Given this list of marker genes OPN3 (opsin 3), VPS45, SIRPB1, ZNF737 (NCBI Gene Id 7655), MYEF2 (myelin expression factor 2), CLDN20, ACIN1, KCNC3, SYNM, NAP1L1, PPCDC, RUFY2, EFNA5, ZNF253, TEK, CREBL2, RIBC1, ULBP1, ZNF680, ZNF732, PISD, GTPBP2, SHISA9, ZNF493, ZNF208, ZNF138, HACD3, MBD6, CAPS2, SDK1, ATP23, ELMOD2, PGM2L1, SMU1, KIF16B, ZNF99, ZNF257, DONSON, NAALADL1, SLC22A10, ZBTB38, SIX4, PDCD4, ICOS, ZNF716, TOP1, NCL, PIP4K2C, MSL1, ZNF506, PLPBP, here is a description of the gene set: Genes predicted to be targets of miRBase v22 microRNA hsa-miR-135a-2-3p in miRDB v6.0 with MirTarget v4 prediction scores > 80 (high confidence targets). from publication Chen Y, Wang X (PMID 31504780) species: Homo sapiens Human Gene Set: MIR135A_2_3P